The following is a description of a gene set: species: Mus musculus Human Gene Set: PIONTEK_PKD1_TARGETS_UP Autosomal dominant polycystic kidney disease is an important cause of end-stage renal disease, for which there is no proven therapy. Mutations in PKD1 (the gene encoding polycystin-1) are the principal cause of this disease. The disease begins in utero and is slowly progressive, but it is not known whether cystogenesis is an ongoing process during adult life. We now show that inactivation of Pkd1 in mice before postnatal day 13 results in severely cystic kidneys within 3 weeks, whereas inactivation at day 14 and later results in cysts only after 5 months. We found that cellular proliferation was not appreciably higher in cystic specimens than in age-matched controls, but the abrupt change in response to Pkd1 inactivation corresponded to a previously unrecognized brake point during renal growth and significant changes in gene expression. These findings suggest that the effects of Pkd1 inactivation are defined by a developmental switch that signals the end of the terminal renal maturation process. Our studies show that Pkd1 regulates tubular morphology in both developing and adult kidney, but the pathologic consequences of inactivation are defined by the organ's developmental status. These results have important implications for clinical understanding of the disease and therapeutic approaches. Genes up-regulated during later stages of renal maturation (days P14-P16) in kidney specific knockout of PKD1. from publication Piontek K, Menezes LF, Garcia-Gonzalez MA, Huso DL, Germino GG (PMID 17965720), and this is the list of marker genes: CYP2D6, TOM1L2, ACSM5, SERPINA2, EGF, HAO2, SGK1, MT1F, SULT1D1P, CCN2, CYP27B1, SLC22A12, ACOX2 (NCBI Gene Id 8309), RDH16, UGT1A6, ERRFI1, TNFRSF21 (TNF receptor superfamily member 21), SLC27A2, SCD, GK, ARG2, PTER, DNASE1, GGCT, SLC13A3, ALDH8A1, NDRG1, UGT3A2, FKBP5, KLF15, ENTPD5, HAAO, KLK1 (NCBI Gene Id 92787), GLUL, MT1X, PRODH, PIM3 (Pim-3 proto-oncogene, serine/threonine kinase), SORD, MPV17L, SLC17A1, AASS (aminoadipate-semialdehyde synthase)